Given this list of marker genes UBA2, ATAD2B, NRXN1, ZNF77, PKN2, CBL, MAP3K2, RFX6, NSUN2, H6PD, YME1L1, GEMIN8, TRPC5, COL11A1, SNX18, INSM1, CLIC5, IRAG2 (inositol 1,4,5-triphosphate receptor associated 2), CALM2, NRN1, AGO4, ZXDA, FRMD3, AXIN2, TMOD1, SPATA13, STT3B, PCDH17, P2RY1, PDCD10, RNF103, USP31, IVNS1ABP, SPIN1, UCK2, USP25, USP15, SLC26A2, KLHL7, AGMO, RRAGA, SBNO2, SRSF6, ITPR1, MAGI1, PIP4P2, ACTR1A, FSBP, SHC1 (NCBI Gene Id 6464), PCNX1, NCAM1, RIMKLA, LIMD2, STRN, CA10, EPS8, SESN3, TRIM44, PSEN2, RFC1, BLOC1S6, ZFX, IL20RA, PLCB1, TST (NCBI Gene Id 96794), SLC18A2, ZIC3, ANKRD12, AGFG1, CNN3 (NCBI Gene Id 1266), MTMR10, CYRIB, KPNA1, NIPA1, FPGS, PTPN1 (NCBI Gene Id 5770), VSIG10, UBE2E3, NR2C2, FNBP1, TECPR2, ATL2, PTPRJ, FUCA1, SOX17, RAB5B, MTX3, DLL1 (NCBI Gene Id 28514), NRP1, JADE1, TENT5D, PPP3CA, TSHZ2, RAP2C, CALU, PALLD, TSPYL5, VCL, NYAP2, KLHL42, ATMIN, CERS2, XYLT1, INPP4A, C2orf80, PHF20L1, HES5, RSPRY1, MXD1, RECQL, TGFBR1, ING1, ZIM3, TMCO3, INSYN2A, SDK2, ZNF737, ITGB1, TNRC6B (NCBI Gene Id 23112), RBFOX2 (NCBI Gene Id 23543), ATL3, LGI1, SKAP1, VIM, ERBB4, TM9SF3, PABPN1, WTAP, NAMPT (NCBI Gene Id 10135), DTD1 (NCBI Gene Id 92675), KAT6A, GATAD2A, NFYB, CDYL2, TFDP2, RNF144A, RAB21, COPZ1, DACT1, LIMS1, BHLHE40, MTR, ATXN1L, USP30, NSUN4, LDB1, SFT2D2, FOXE1, RAB43, SERINC5, SOS1, MRTFB, FUNDC2, SLC9A2, GATA6, CC2D1B, AGO3, RBMS1, KCNA1, AKAP13, POLR1C, SH3PXD2A, DENND1B, NUP50, GDAP1L1, NKIRAS1, APIP, C9orf72, SMAD4, SACM1L, CERT1, SSH2, C5orf24, GABRA2, NME4, C2orf69, ARL5B, ZNF117, NFIB, PGS1, OXCT1, TLCD4, RCAN2, CBY1, RFX3, AMER1, MBD2, IDO2, LARP1B, TUBGCP3, RICTOR, NEXMIF, GLUD2, EIF4A2, TNFSF11, PIK3C2A, RAPGEF5, HS6ST2, TMEM128, NR1D2, FBXO42, PTBP3, SERTAD2, PDE2A, GALNT1, ARPC3, TENM1, CECR2, FRMD6, CNOT4, LRRC7, CBX2, SOX8, ING2, SLC30A7, RNPC3, SMARCC1, PBRM1, EGR1, ZNRF3, OSTM1, FABP3, HIVEP3, WDR6, ARHGAP44 (NCBI Gene Id 9912), TMEM47, SENP5 (NCBI Gene Id 205564), ZNF550, KCTD12, TMEM33, FZD3, PRRC2C, ZBTB41, ANTXR1 (ANTXR cell adhesion molecule 1), DAG1, TUB, HYCC2, MYO1E, PTPN11, METAP2, UBE2E1 (NCBI Gene Id 94682), SPRY3, TMEM70, GLRA2, PEG3, IQGAP2, SNX30, LPP, BMPR1A, GRK3 (NCBI Gene Id 157), SLCO3A1 (NCBI Gene Id 28232), RAB8B, MTCL2, USP9X, CLOCK, UBQLN2, YTHDF3 (NCBI Gene Id 253943), ZNF236, NETO1, CEP162, EPN2, CCDC40, RDX, CORIN, KAT6B, PAX5, PRTG, VAPA, TAB3, ANKLE2, CCSAP, KLF7, RIMBP2, RFX4, WDR33, GRB2, PCMTD2, PAK5, GALNT10, APH1A, INO80D, RSAD2, ING3, ZNF518A, GOLGA3, PTGFR, TNFSF13B, CCDC144NL, ABHD17B, ST6GALNAC5, REEP1, IQGAP1, SRF, PCDHB4, PIGM, CD69, BAG1, TFEB, GPM6B, DUSP19, SUMO3, SLC37A1, PCDH7, SCN7A, FAM13B, PDE4B, SVIP, FZD4, MLF2, PARD3, PLP2, STK24, ATF7, CCNE1, GOLGA1, KCNS2, SCML4, SKP2, ELL2, RAB11FIP1, MCTP1, ZNF532, DYNC1LI2, SGPP1, MBNL3, ETV5, IMPACT, SNTA1, KIF3A, FERMT2, KPNA3, H2AZ1, TTC17, BEND4, FAM98A, B3GNT2, SLF2, ATXN7, CDH2, ANTXR2, USP37, SYNJ2BP, MZT1, LBH, ESRRG, GLUD1, HIVEP1 (NCBI Gene Id 3096), PRR15L, MTUS1, RELCH, IGF1R, IGF2R, STAG1, CREBBP, BBX, POLR3B, POLQ, EVI5 (NCBI Gene Id 7813), RHOBTB1, CDH4, CILP, KLHL15, MMD, SRGAP1, SP1, TBC1D20, ZMAT3, LRRC8B, FBXO38, ENDOD1, PIGN, LRRC8C, GATAD2B, NIPAL3, ETS2 (ETS proto-oncogene 2, transcription factor), PAK2, PATL2, CBLB, ARL6IP5, TULP4, ZNF333, SEPHS1, NEMP1, STK26, VAPB (VAMP associated protein B and C), ZNF107, HP1BP3, SYNCRIP, BCL2L2-PABPN1, PAPSS2, SLC7A14, VAMP3, C1GALT1, SOS2, CHSY3, TM9SF1, CNOT9, PIM1 (Pim-1 proto-oncogene, serine/threonine kinase), AMER2, ZBTB44, HECTD2, SNX6, JADE2, RHOU, SDC2, IKZF4, FCGR2A, B4GALT1, VPS35, TET1, ALG5, AFF4, PPARGC1A, NFAT5 (nuclear factor of activated T cells 5), RIT2, WBP11, CTDSP2, NUP153, ADAM22, CXADR, SMIM17, MACO1, TRAPPC2L, JPH3, CARMIL1, UBN1, GPATCH2L, LBR, SSB, PTPN14, EAF1, UFM1, PAPOLA, CLCA2, KDELR1, TET2, LRCH1, PAQR9, ATP8A1, OSBPL8, MIER3, SH3D19, SPO11, NFIA, ATP6V0E1, ZDHHC6, CTXN1, CSMD1, PHC3, NWD1, CIT, CACNB4, CDON, NT5E, NCBP2, CDHR3, BEX3, FAM171A1, PROX1, ASCL1, TEAD1, ATP2B1, RER1, ELL, GPR158 (NCBI Gene Id 57512), GLCCI1, PUS7, SEL1L, GRAMD1C, SH3BGRL2, PHACTR1 (NCBI Gene Id 81705), HNRNPA2B1, OSBPL10, AK3, CEP350, FAM91A1, RABGEF1, TM2D2, RNF135, GALNT12, ZYG11B, CAMK1D, CCDC177, CHD1, here is a description of the gene set: Genes predicted to be targets of miRBase v22 microRNA hsa-miR-548an in miRDB v6.0 with MirTarget v4 prediction scores > 80 (high confidence targets). species: Homo sapiens Human Gene Set: MIR548AN from publication Chen Y, Wang X (PMID 31504780)